The following is a description of a gene set: Genes having at least one occurence of the motif ATCTTGC in their 3' untranslated region. The motif represents putative target (that is, seed match) of human mature miRNA hsa-miR-31 (v7.1 miRBase). Human Gene Set: ATCTTGC_MIR31 studied in species Homo sapiens, and this is the list of marker genes: SLC35A3, SLITRK4, EVC, TMEM35A (NCBI Gene Id 59353), CPSF6, PPP2R2A, UHMK1, PAFAH1B1, NNAT, BEST1, CXCL12, SNX22, EED, RHOA, WAC, DCBLD2, ZFAND6 (NCBI Gene Id 54469), GATAD2B, ZFP36L1, NEXMIF, ATP8B5P, CADPS, FAM120A, MIDEAS, DAAM1, SRSF1, ADAM28, UBE2E1, VGLL3, SETD3, PTPRE, FZD3, IGSF22, PLCB1, C1QL3, TM9SF3, FGF7P6 (fibroblast growth factor 7 pseudogene 6), IGSF11, GRM7, FNDC5, DESI2 (NCBI Gene Id 51029), ABCB9, IL34, SET, ADNP (activity dependent neuroprotector homeobox), DIP2C, NUMB, UHRF2, CTDSPL2 (NCBI Gene Id 51496), SEMA3F, RSBN1, SPTSSA, ARID4A, BAZ1B, TMEM132E, HERPUD2, RAB37, CAMK1D, BACH2, SLTM, JMJD8, SLC17A6, CEP350, TACC1, HHIPL2, G3BP2, MPRIP, SLC26A2, AMD1, STRN3, YY1, TMEM243, SPRED1, RBM14, TULP4, PPP4R3A, TMEM248